Given this list of marker genes Trim21, Otop1, Clec12b, Bcr, Slamf1, Foxp3, Wdr41, Igf2, Muc4, Tgfb1, Rc3h2, Zfp35, Inpp5d, BC037156, Mndal, Gigyf2, Stat2, Trafd1, Dhx58, Ifi206, Ceacam1, Serpinb9g, Nlrp4f, Oas1e, Oas1f, Ywhaz, Enpp3 (ectonucleotide pyrophosphatase/phosphodiesterase 3), H2-M3, Ppp3cb, Nlrp6, Rps19, Smad7, Zc3h12a, Susd4, Mavs, Ythdf2, Nectin4, Samsn1, Cd55b, Atg12, Irf1, Pf4, Il7r, Serpinb9c, Ins1, Pglyrp3, Cr2, Samhd1, Pglyrp4, Ttll12, Cd300a, Oas1c, Clec2d, Usp15 (NCBI Gene Id 70921), Parp3, Serpinb9, Nmi, Ascl2, Drd2, Sh2d1b2, Gpx2 (NCBI Gene Id 14776), Nlrx1, Clec4g, Mmp12, Anxa1, Usp38, Olfm4, Parp14, Ddx39a (NCBI Gene Id 68278), Spi1, Cnot7, Serpinb9h (NCBI Gene Id 544923), Pparg, Slamf8, Atg5, Pim1, Lgals3, Lilrb4b, Rc3h1, Fcrlb, Nlrp4b, Tap1, Serpinb9e, Usp18 (NCBI Gene Id 68782), Pglyrp1, Tnfsf4, Dtx4, Il12b, Smim30, Ptprc, Cd80, Cep63, Tyro3, Ifi214 (interferon activated gene 214), Loxl3, A2m, Dnaja3, Cd274, Alox15, Vsig4, Sh2d1b1, Nckap1l, Aurkb, Cd96, Col3a1 (collagen, type III, alpha 1), Cd160, Ptpn2, Ifi209, Npy, Adar, Ifi203, Fer, Oas1a (NCBI Gene Id 246730), Lilrb4a, Ifi207, H2-T23, Spn, Il10, Bcl6, Il27ra, Ndfip1, Smcr8 (Smith-Magenis syndrome chromosome region, candidate 8 homolog (human)), Klrd1, Parp1, Zp3r, Ins2, Nlrc3, Il33, Grb2, Cd55, Psma1, Nlrp4a, Dusp10, Nectin2, Vsir, Dcst1, Arg2, Socs5, Gfer, Zdhhc18 (zinc finger, DHHC domain containing 18), Lgals9, Serping1, Ifi203-ps, Jak3, C9orf72, Lyar, Il20rb, Gpr17, Nlrp4c, Cd59a, Arrb2, Banf1, Il4i1, Trex1, Ccr1, Ifi213, Cr1l, Ythdf3, Hlx, Ccr2, Serpinb9b, Zbtb7b, Psmb4, Arg1, Acod1, Klre1, Foxj1, Ptpn6, Mul1, Oas1b, Pdcd1, Tnfaip3, Mkrn2 (makorin, ring finger protein, 2), Dusp22, Crk, Sfn, Adcyap1, Klrb1b, Trem2, Ifnb1, Il4, Oas3, Npy5r, Smpdl3b, Serpinb9f, Cd59b, Hfe, Nlrp4e, Il1rl1, C4bp, Lgals1, Ufl1, Oas1d, Fgl2, Mill1, Irak3, Trim27, Il2, Isg15, Eif4e2, Tbx21, Abr, Cd46, Serpinb9d, Tnfsf18, Fam3a, Ifi208, Cd69, Oas1g, Oas1h, Havcr2, Selenos, Mettl3, Fcgr2b, Gpx1, Nlrc5, Ahr (aryl-hydrocarbon receptor), Pglyrp2, Il4ra, Nod2, Tap2, Grn, Tnfrsf14, Cactin, Masp1, Stat6, here is a description of the gene set: Any process that stops, prevents, or reduces the frequency, rate or extent of the immune response, the immunological reaction of an organism to an immunogenic stimulus. studied in species Mus musculus Mouse Gene Set: GOBP_NEGATIVE_REGULATION_OF_IMMUNE_RESPONSE